The following is a description of a gene set: External mechanical compression of the spinal cord. studied in species Homo sapiens Spinal cord compression Human Gene Set: HP_SPINAL_CORD_COMPRESSION, and this is the list of marker genes: CCND1, LIN28B, B3GALT6, BRAF, IDUA, SLC26A2, FLNB, HABP2 (hyaluronan binding protein 2), PHEX, NEPRO, B2M, SOX5, ZEB2, GBA1, DNA2, NRAS, HBB (NCBI Gene Id 3043), GNAS, MINPP1, MYCN, RAF1, EXTL3, PHOX2B, EXT2, DDR2, KIF1B, COMP, COL2A1, RMRP, AKT1, IDS, FOXE1, SCARB2, NFIX, ARSL, EXT1, LMO1, COG4, APC (NCBI Gene Id 324), ALK, HACE1, TRPV4, CREBBP, EP300